The following is a description of a gene set: Mouse Gene Set: GOBP_POSITIVE_REGULATION_OF_NEUTROPHIL_MIGRATION Any process that activates or increases the frequency, rate or extent of neutrophil migration. species: Mus musculus, and this is the list of marker genes: Ccl21f, Mdk, Tlr2, Perp, Dapk2, Nckap1l, Mospd2, Dysf, Dnm1l, Rac1, Thbs4, Ccl19-ps6, Ccl21d, Ccl19-ps1, Rac2, Selenok, Il1a, Fut4, Ccl21a, Ccl19-ps4, Ptger3, Cd99l2, C1qbp (complement component 1, q subcomponent binding protein), Camk1d, Ccl19, Sell, Il23a, Adam8, Cd74 (CD74 antigen (invariant polypeptide of major histocompatibility complex, class II antigen-associated)), Ccl19-ps3, Ccl21e, Ccl19-ps5, Edn1, Ccr7, Ccl21b, C3ar1, Il1b, Il1r1, Lbp, Myo1f, C5ar1, Ednra, Xcl1, Ripor2, Fut7, Tirap, Mcu, Rtn4, Pawr (PRKC, apoptosis, WT1, regulator), Ptger4, Cxcr2